Given this list of marker genes PRADC1, TTLL5, REEP4, MEX3B, SDE2, MRPS18A, RAD51C, TNNT1, DDAH2, CEP43, ACSL3, UBE2J1, PDE2A, SMC3, ATAD1, MRPL54, HSBP1 (NCBI Gene Id 3281), SAPCD2, HIVEP3 (NCBI Gene Id 86368), NKX2-5, PRDM4, RASSF3, ZFAND4, PRDX5, MIS18A, TUFT1, DSN1, NCOA1, TBC1D31, RTN4IP1, LRRC36 (leucine rich repeat containing 36), PHF6, ERI1, PBDC1, PSMA1, AIDA, DUSP4, BPGM, ZBTB2, SCAF11, SMCO4, GAMT, IMMT, MRPL46, ZFTA, CSNK1E, WFDC2, PPP2CA, PREP, ZFAT, FUNDC1, PER1, PLEKHO2, UBE2L3, FAM83F, GPD1L, PEDS1, DMWD, LRP8 (LDL receptor related protein 8), IFT57 (intraflagellar transport 57), YY1, RNF41, SLC25A13, CENPF (NCBI Gene Id 51468), DNM3, ATXN7L1, MND1, HERPUD1, CENPH, AIF1L, MIER1, ANP32B, TYMS, CDC42EP3, RIF1, DHCR24 (24-dehydrocholesterol reductase), EFNB1, ASRGL1, RHOA, NME7, NR4A3, SLC15A3, GNA13, IFT80, LGALS1, LMNB1, TARS3, RNF19B, PLEK, SLC1A4, PIK3CG, CTLA4, CITED2, NOTUM, LRRC23, TIMM17B, IQGAP3, KCTD17, TOMM22, DTWD2, COX6B1 (cytochrome c oxidase subunit 6B1), CENPV, SLC43A3, HEXIM1, DPYSL2 (dihydropyrimidinase like 2), NT5C3B, DYNC2H1 (NCBI Gene Id 79659), MBNL3, EYA3, PADI4, USP37, BUB3, TIMM23, CNOT1, RRM2B, FADS2, B3GNT9, ACTN4, ZFP36L2, RAF1, H2AZ1, SLC66A3, FCER2, SCCPDH, REL, NBN, ZNF496, MSH6, ENY2 (NCBI Gene Id 56943, ENY2 transcription and export complex 2 subunit), NPEPPS, TP53I11, EPN2, TICRR, GLA, UBE2H, GMPS, ELMO1, PHKA2, LMF2 (lipase maturation factor 2), LSM3, NPLOC4 (NPL4 homolog, ubiquitin recognition factor), RNASEH2B, LYAR, CDKN2A, ELOF1 (elongation factor 1), IGHM, PCYT1B, E2F5, ATP6V1E1, LSM14A, TGIF1, C4orf46, BRWD3, VPS35, BTNL2 (NCBI Gene Id 56244), TOP2B, CKB, IRAG2, LSM1, TP53INP2, FAM76B, TERF2IP, DUSP3, RAB9A, MTHFD2, FADS3, RAD23B, HDAC1, FBXO2, SLC12A2, KNL1, PAIP2, MDM1, GMNN, CDC14B, HYPK, LSM2, HIPK3, SPEF1, EIF4H, SUMO3, CSRP1, ZW10, FAS, CEP76, DPH3, INTS13, SUV39H2, FAM167B, ILDR1, FCHSD2, NADK2, MC1R, PHF13, RETREG1 (NCBI Gene Id 96119), KRT222, TRAIP, ROS1, TM4SF5, here is a description of the gene set: Human Gene Set: GSE411_UNSTIM_VS_400MIN_IL6_STIM_SOCS3_KO_MACROPHAGE_DN from publication Lang R, Pauleau AL, Parganas E, Takahashi Y, Mages J, Ihle JN, Rutschman R, Murray PJ (PMID 12754506) Genes down-regulated in macrophages with SOCS3: untreated versus IL6 for 400min. studied in species Homo sapiens Effects of SOCS3 on the transcriptional response of bone marrow-derived macrophages to IL-6. Fetal liver cells from SOCS3+/+ or SOCS3-/- embryos were used to reconstitute recipient mice. Donor derived bone marrow from these mice was differentiated to macrophages. Macrophages were either unstimulated, or stimulated for 100 or 400 minutes with 10 ng/ml IL-6.